Given this list of marker genes Gck, Grb10, Gfpt1, Dyrk2, Enpp1, Ndst1, Mtor (NCBI Gene Id 80612), Gys2, Irs1, Ppp1r3f, Has1, Esrrb (NCBI Gene Id 26380), Tgfb1, Ap2a1, Ins1 (insulin I), Smpd3, Pask, Gys1, Fut9, Nfkb1, Irs2, Ppp1r3b, Ext2, Insr, Egf, Akt1, Ppp1r3c, Ppp1ca, Igf1, Has3, Prkag3, Igf2, Pdgfb, Gsk3b (glycogen synthase kinase 3 beta), Ppp1r3d, Ppp1r3e, Has2, Sorbs1 (sorbin and SH3 domain containing 1), 1810024B03Rik, Epm2a, Ptges3, Inpp5k, Nr1d1, Pgm1, Cltc, Pth, Ppp1r3g, Gyg1, Ext1, Pgm2, Nhlrc1, Gbe1, Ins2, Acadm, C1qtnf2, Akt2, Epm2aip1, Ugp2, Ptger4, Ppp1r3a, Ppp1cb, Per2, here is a description of the gene set: Mouse Gene Set: GOBP_POLYSACCHARIDE_BIOSYNTHETIC_PROCESS studied in species Mus musculus The chemical reactions and pathways resulting in the formation of a polysaccharide, a polymer of many (typically more than 10) monosaccharide residues linked glycosidically.